Given this list of marker genes OPN5, CNGB3, PDE6B, GUCA1B, PIP4K2A, MAP1B, SPATA7, PCDH15, IFT20, OPN4, GNAT2, PDC, PRPH2, RPGR, CERKL, ROM1, OPN1MW2, IQCB1, STX3, MYRIP, MERTK, DHRS3, PCDHB13, CRB1, GRK4 (G protein-coupled receptor kinase 4), TMEM237, GNB1, GUCA1ANB-GUCA1A, RHO, GNGT1, ATP1A4, MYO7A, GUCY2D, RGS9BP, BBS7, GNAQ, BSG, OPN1SW, RCVRN, INHA (inhibin subunit alpha), IMPG1, NXNL1, PRCD, MAK, OPN1MW (NCBI Gene Id 2652), CEP250, PPEF2, RP1, TULP1, MAGI2, OPN1LW (NCBI Gene Id 8261), PROM1, ARR3, PHLPP2, OPN1MW3, GNA11, GRK7, VCAN, GNAT1, KIF17, CNGB1, PCARE, KIFAP3, SHANK2, OPN3, SLC24A4, PDE6A, GUCA1A, CNGA1, CFAP410, NAPEPLD, CACNA1F, WDR19, SPTBN5, PEX6, RAB27A, OCRL, GUCY2F, EYS, ABCA4, CCDC66, SAG (S-antigen visual arrestin), PTGS1, CDHR1, PDE6G, USH1C, IFT140, RP1L1, CIB2, RD3, GUCA1C, BBS4, GRK1, PDE6H, LYAR, here is a description of the gene set: Human Gene Set: GOCC_PHOTORECEPTOR_OUTER_SEGMENT species: Homo sapiens The outer segment of a vertebrate photoreceptor that contains a stack of membrane discs embedded with photoreceptor proteins.